The following is a description of a gene set: electronically inferred by orthology from the curated human pathway species: Mus musculus Reactome Pathway: Opsins This event has been computationally inferred from an event that has been demonstrated in another species.<p>The inference is based on the homology mapping from PANTHER. Briefly, reactions for which all involved PhysicalEntities (in input, output and catalyst) have a mapped orthologue/paralogue (for complexes at least 75% of components must have a mapping) are inferred to the other species. part of: Class A/1 (Rhodopsin-like receptors), and this is the list of marker genes: Opn4, Opn3, Rho, Opn5, Opn1sw, Rgr, Rrh